The following is a description of a gene set: Human Gene Set: GOBP_REGULATION_OF_MEMBRANE_REPOLARIZATION_DURING_ACTION_POTENTIAL Any process that modulates the rate, frequency or extent of membrane repolarization during an action potential. Membrane repolarization is the process in which membrane potential changes in the repolarizing direction, towards the resting potential. species: Homo sapiens, and this is the list of marker genes: CASQ2, CACNA2D1, RNF207, NOS1, FLNA, MIR1-1 (microRNA 1-1), CACNB3, KCNE3, NOS1AP, MIR133A1, MIR328, CAV1